The following is a description of a gene set: studied in species Mus musculus Mouse Gene Set: GOBP_NEGATIVE_REGULATION_OF_TUMOR_NECROSIS_FACTOR_SUPERFAMILY_CYTOKINE_PRODUCTION Any process that stops, prevents or reduces the frequency, rate or extent of tumor necrosis factor superfamily cytokine production., and this is the list of marker genes: Trem2, Fxr1, Akap8 (NCBI Gene Id 67462), Gas6, Sirt1, Nfkbil1, Gpr18, Chrna7, Hsf1, Tlr6, Clec4a4, Il4, Clec4a2, Elf4, Trim27, Lbp, Havcr2, Slamf1, Pomc, Nlrc3, Errfi1, Il10, Igf1 (insulin-like growth factor 1), Ptpn22, Foxp3, Twist1 (twist basic helix-loop-helix transcription factor 1), Nr1h4, Zc3h12a, Adipoq, Twist2, Ghrl, Ptpn6 (protein tyrosine phosphatase, non-receptor type 6), Nod2, Irak3, Acp5 (NCBI Gene Id 11433), Rara, Axl, Cx3cl1, Trim30a, Ltf, Cd24a, Lilrb4a, Bpi, Cidea, Tlr4 (NCBI Gene Id 21898), Arrb2, C5ar2, Cd274, Gstp3, Dicer1, Bcl3, Selenos, Arg2, Sirpa, Gstp-ps, Tspo, Gstp2, Tnfaip3, Ghsr, Syt11, Ptger4, Mc1r, Vsir, Cactin, Lilrb4b, Rad21, Gstp1, Hdac3, Clec4a3, Il27ra, Gpnmb, Ilrun, Flt3